Given this list of marker genes CCND1, ESR1, NCOA1, NCOA3, MYC (MYC proto-oncogene, bHLH transcription factor), here is a description of the gene set: Pathway Definition from KEGG: E2 -> (ESR*+(NCOA3,NCOA1)) => (CCND1,MYC) ESR1-positive to nuclear-initiated estrogen signaling pathway. Pathway ID: N00287. Pathway type: Variant. Pathway class: nt06270 Breast cancer. studied in species Homo sapiens Human Gene Set: KEGG_MEDICUS_VARIANT_ESR1_POSITIVE_TO_NUCLEAR_INITIATED_ESTROGEN_SIGNALING_PATHWAY